Given this list of marker genes COL9A3, SLC39A13, SLC29A3, EIF2AK3, CHST3, ACP5, POLR3A, NANS, PAPSS2, ZBTB20, TRAPPC2 (NCBI Gene Id 6399), TCIRG1, CCN6, GORAB, RNU4ATAC, COL9A1, KIF22, TNFRSF11A, MMP13, COL2A1, EXOC6B, COL10A1, COG4, GNPAT, COMP, ZFX, SLC10A7, COL9A2, PDE4D, IDH1, B3GALT6 (NCBI Gene Id 126792), here is a description of the gene set: studied in species Homo sapiens An irregular surface of the vertebral end plates, which are normally relatively smooth. Irregular vertebral endplates Human Gene Set: HP_IRREGULAR_VERTEBRAL_ENDPLATES